The following is a description of a gene set: studied in species Homo sapiens Human Gene Set: GOMF_PHOSPHOLIPASE_A2_ACTIVITY Catalysis of the reaction: a 1,2-diacyl-sn-glycero-3-phospholipid + H2O = 1-acyl-sn-glycero-3-phospholipid + a fatty acid. This reaction removes the fatty acid attached to the sn2-position. Substrates include phosphatidylcholine, phosphatidylethanolamine, choline plasmalogen and phosphatides., and this is the list of marker genes: PLA2G6, PLA2G7, PRDX6, PROCA1, PLAAT4, PLA2G4F, PLA2G12B, PLA2G10, PLA2G3, OC90, ANXA8, PNPLA2, PLA2G4B, PLAA, PLB1, PLA2G12A, PNPLA4 (patatin like phospholipase domain containing 4), CASP3, PLA2G1B, ANXA2, PLAAT1, PLA2G4C, PNPLA8, PLAAT5, PLA2G4A, PLA2G5, LCAT, PLA2G2A, PLA2R1, ABHD3, PLAAT2, PLA2G2C, PLA2G2E, ANXA1 (NCBI Gene Id 301), PLA2G4E, PLAAT3, PLA2G2F, PLA2G2D, PLA2G4D (phospholipase A2 group IVD), PNPLA3, ANXA3, PGAP6, PLA2G15 (phospholipase A2 group XV), SCGB1A1